Given this list of marker genes Wnt5a, Agt, Nrxn1, Tcim, Cemip, Egfr, here is a description of the gene set: Any process that modulates the frequency, rate or extent of protein kinase C activity. Mouse Gene Set: GOBP_REGULATION_OF_PROTEIN_KINASE_C_ACTIVITY studied in species Mus musculus